Given this list of marker genes Il6, Gas6, P4hb, Serpind1, Bmp4, Gpc3, Apol7b, Apob, Afp, Apoe, Fstl1, Tnc, Prss23, Apoa5, Mxra8, Apol10a (apolipoprotein L 10A), Cst3, Enam, Prkcsh, Igf2, Fstl3, Lgals1, Apoa1, Proc, Rcn1, Hrc, Hsp90b1, Apoa2, Ktn1, Fgf23, Igfbp3, Apol9a, Apol8, Serpina10, Ckap4, Apol7a, Wfs1, Tmem132a, Mfge8, Scg2 (NCBI Gene Id 20254), Sparcl1, Apol10b (NCBI Gene Id 328561), Penk, Apol9b, Ahsg, Amelx, Fam20a, Cdh2, Ano8, Fgg, C3, Msln, Alb, Igfbp7, Notum, C4b, Aplp2, Spp2, Trf, Scg3, Chgb, Apol11b, Kng2 (NCBI Gene Id 385643), Matn3, Meltf, Apol7e, Vgf, Mepe (NCBI Gene Id 94111), Men1, Chrdl1, Spp1, Amtn, Timp1, here is a description of the gene set: studied in species Mus musculus Reactome Pathway: Regulation of Insulin-like Growth Factor (IGF) transport and uptake by Insulin-like Growth Factor Binding Proteins (IGFBPs) part of: Metabolism of proteins This event has been computationally inferred from an event that has been demonstrated in another species.<p>The inference is based on the homology mapping from PANTHER. Briefly, reactions for which all involved PhysicalEntities (in input, output and catalyst) have a mapped orthologue/paralogue (for complexes at least 75% of components must have a mapping) are inferred to the other species. electronically inferred by orthology from the curated human pathway